The following is a description of a gene set: Human Gene Set: BUSSLINGER_DUODENAL_GOBLET_CELLS species: Homo sapiens from publication Busslinger GA, Weusten BLA, Bogte A, Begthel H, Brosens LAA, Clevers H (PMID 33691112), and this is the list of marker genes: ITLN1, AGR2, FCGBP, BCAS1, ST6GALNAC1, TFF3, SPINK4 (NCBI Gene Id 27290), RNASE1, LINC00261, REG4, CLCA1, MUC2, LYZ, EGR1 (NCBI Gene Id 1958), HPCAL1, CREB3L1